Given this list of marker genes Klf4, Acta2, Adipor2, Chchd10, Marcks, Nrp1, Lum, Derl1, Aldh1a7, Dpt, Gpam, Pde8a, Ccl11, Gpd2, Ptges, Cpt2, Phyh, Gyg1, Acaa2, Rspo1, Chpt1, Sowahc, Htra1, Acaa1a, Hadh, Col6a3, Heph, Ugt1a2, Srpx, Aplp2, Atp1b3, Pgm1, Tsc22d1, Gpx3, Cavin2, Tmem43, Penk, Phldb1, Bckdhb, here is a description of the gene set: Down-regulated genes from the 65 most significantly changed (p<0.01) genes identified by two analytical methods in the mammary tumors induced by transgenic expression of ERBB2. Mouse Gene Set: LANDIS_ERBB2_BREAST_TUMORS_65_DN from publication Landis MD, Seachrist DD, Montañez-Wiscovich ME, Danielpour D, Keri RA (PMID 15897883) Upregulation of HER2/ErbB2/Neu occurs in 15-30% of human breast cancers and correlates with poor prognosis. Identification of ErbB2/Neu transcriptional targets should facilitate development of novel therapeutic approaches. Development of breast cancer is a multistep process; thus, to identify the transcriptomes associated with different stages of progression of tumorigenesis, we compared expression profiles of mammary tumors and preneoplastic mammary tissue from MMTV-Neu transgenic mice to expression profiles of wild-type mammary glands using Affymetrix microarrays. We identified 324 candidate genes that were unique to ErbB2/Neu-induced tumors relative to normal mammary gland tissue from wild-type controls. Expression of a subset of these genes (82) was also changed in the preneoplastic mammary glands compared to wild-type controls, indicating that they may play a pivotal role during early events of ErbB2/Neu-initiated mammary tumorigenesis. Further analysis of the microarray data revealed that expression of several known transforming growth factor (TGF)-beta target genes was altered, suggesting that the TGF-beta signaling cascade is downregulated in ErbB2/Neu-induced tumors. Western blot analysis for TGF-beta-Receptor-I/ALK5 and immunohistochemistry for TGF-beta-Receptor-I/ALK5 and phosphorylated/activated Smad2 confirmed that the Smad-dependent TGF-beta signaling cascade was inactive in these tumors. Although absent in most of the tumor, phosphorylated Smad2 was present in the periphery of tumors. Interestingly, presence of phosphorylated/activated Smad2 correlated with expression of Activin-Receptor-IB/ALK4, suggesting that although Smad-dependent TGF-beta signaling is absent in ErbB2/Neu-induced tumors, Activin signaling may be active at the leading edge of these tumors. Cumulatively, these data indicate that the TGF-beta pathway is intrinsically suppressed in ErbB2/Neu tumors via a mechanism involving loss of TGF-beta-Receptor-I/ALK5. studied in species Mus musculus